The following is a description of a gene set: Genes up-regulated in metastatic breast cancer tumors having type 2 amplification in the 20q13 region; involves MYBL2, STK6 and ZNF217 species: Homo sapiens PURPOSE: Amplification of chromosomal region 20q13 occurs in breast cancer but remains poorly characterized. EXPERIMENTAL DESIGN: To establish the frequency of 20q13 amplification and select the amplified cases to be studied, we used fluorescence in situ hybridization of bacterial artificial chromosome probes for three 20q13 loci (MYBL2, STK6, ZNF217) on sections of tissue microarrays containing 466 primary carcinoma samples. We used Affymetryx whole-genome DNA microarrays to establish the gene expression profiles of 20q13-amplified tumors and quantitative reverse transcription-PCR to validate the results. RESULTS: We found 36 (8%) 20q13-amplified samples. They were distributed in two types: type 1 tumors showed ZNF217 amplification only, whereas type 2 tumors showed amplification at two or three loci. Examination of the histoclinical features of the amplified tumors showed two strikingly opposite data. First, type 1 tumors were more frequently lymph node-negative tumors but were paradoxically associated with a poor prognosis. Second, type 2 tumors were more frequently lymph node-positive tumors but were paradoxically associated with a good prognosis. Type 1 and type 2 showed different gene expression profiles. No 20q13 gene could be associated with type 1 amplification, whereas several 20q13 genes were overexpressed in type 2 tumors. CONCLUSIONS: Our results suggest that amplified tumors of types 1 and 2 are two distinct entities resulting from two different mechanisms and associated to different prognosis. from publication Ginestier C, Cervera N, Finetti P, Esteyries S, Esterni B, Adélaïde J, Xerri L, Viens P, Jacquemier J, Charafe-Jauffret E, Chaffanet M, Birnbaum D, Bertucci F (PMID 16899599) Human Gene Set: GINESTIER_BREAST_CANCER_20Q13_AMPLIFICATION_UP, and this is the list of marker genes: PARD6B, SMAD5, BNIP3L, BAIAP3, ZNF587, TPR, RBM39, PRRC1, PSMA7, IFT22, RNASE4, PDP1, ARFGEF3, AZI2, UBBP1, GINM1, DAAM1, SMIM14, ENPP1, ZNF217, ELP2, ARFGEF2, DSCR10, ATP2B4, TMEM218, STAG2, CACNG4, ADD1, KLF9, MAPT, TCAF1, DMAC2, MORF4L2, ZNF91, ROMO1, SNORA71B, SPATA24, KCTD20, ZNF148, ZNF552, ESR1, LINC00491, RSPH3 (radial spoke head 3), PPP1R3D, DMAC2L, EMILIN3, TMED4, SERINC3, KLHL8 (NCBI Gene Id 57563), DPM1, DNAJC21, BLOC1S6, TSHZ2, GRID1, SLC39A6, BLVRB, HSPB1, TALAM1, ODR4, ZBTB8A, ERGIC3, RHOBTB3, CDS1, DIXDC1, DNAJB14, ADNP, BCAS4, ATP5F1E, MLLT10, CFD, UQCC1 (ubiquinol-cytochrome c reductase complex assembly factor 1), SPPL2A, TOX4, PFDN1, MAP3K12 (NCBI Gene Id 7786), TAF1, TMBIM4, CTNNBL1, RAPH1, FNIP1, STAU1, ITPRIPL2, PDP2, RBM3 (RNA binding motif protein 3, NCBI Gene Id 5935), POSTN, ADCY1, MTG2, YIPF5, SEC62, LEPROT, MAGT1, KIF5B, DNAL1, CAVIN2, STX16, HSP90AA1, YWHAB, LIN52, RDH11, SLC4A7, UHMK1, FITM2, C20orf141, SYDE2, F2R, DDX27, AP1AR (NCBI Gene Id 55435), EFCAB11, ADH4 (NCBI Gene Id 127), NCOA3